The following is a description of a gene set: species: Homo sapiens Human Gene Set: HP_GASTROINTESTINAL_ATRESIA Gastrointestinal atresia, and this is the list of marker genes: PLEC, PIGN, ARNT2, IFT80, YY1, COX7B, RERE, PAICS, EFTUD2, GLI2, FANCD2, PI4KA, SON, SIN3A, DIS3L2 (NCBI Gene Id 282696), FGF8, NODAL, PTCH1, CENPF, PPP1R12A, ZIC2, CHD7, BUB3, DYNC2H1, FOXF1, FANCL, ERCC4, TCTN3, SIX6, CEP57, CHRM3, FOXH1, DYNC2I2, FGFR2, DYRK1A, STAG2, DLL1, SOX2, SLC25A12, CFAP45, RMRP, TRIP13, SMARCD1, MYCN, PROKR2, KDM3B, FGFR1 (NCBI Gene Id 84151), AP1S1, FANCB, FANCF, SPINK5, POLA1, BUB1B (BUB1 mitotic checkpoint serine/threonine kinase B), CAMK2A, CDON, RFX6, SHH, MIR17HG, GAS1, SALL1, TGIF1, FLI1, ITGA6, OTX2, WBP11, WDR35, HCCS, FBN2, TTC7A, ZIC3, PORCN, RTTN, ZNF699, HESX1, ITGB4, SIX3, SOX3, DISP1, AR, RFWD3, CRIPTO, NDUFB11, MAMLD1, SUFU, BUB1, PAH, FREM2, MYH11, DYNC2I1, RAD51C, GMPPB, FANCI, CLMP